The following is a description of a gene set: Genes down-regulated in CD4 T cells over-expressing FOXP3 and PPARg1 form of PPARG: untreated versus pioglitazone. Human Gene Set: GSE37534_UNTREATED_VS_PIOGLITAZONE_TREATED_CD4_TCELL_PPARG1_AND_FOXP3_TRASDUCED_DN Pioglitazone treatment of CD4+FoxP3- T cells transduced with Pparg and Foxp3 up-regulated a set of genes whose products have been implicated in lipid metabolism pathways. To verify the specificity of this treatment, we performed microarray analysis on Foxp3+Pparg1-transduced CD4+FoxP3- T cells after treatment with other PPARg agonists such as Rosiglitazone (TZD) and GW1929 (non-TZD). studied in species Homo sapiens from publication Cipolletta D, Feuerer M, Li A, Kamei N, Lee J, Shoelson SE, Benoist C, Mathis D (PMID 22722857), and this is the list of marker genes: CXCL10, MYD88, NAGK, KIF5C, ISG15, RNF19B, H2BC4, GTPBP2, GCH1, SYNRG, APOL2, FRS2, BRCC3, HERC6, MRPL17, GSDMD, CFLAR, STK19, GNAZ, WARS1, VAMP5, HLA-J, UBE2L6, JADE2, ERAP1, IFI30, TAP2, ATP10A, IFI35, CENPN, TMEM140, C1S, IFITM1, LGALS8, CARHSP1, CBR1, CASP1, OAS1, CRADD, FST, MT1M, STARD5, DCP1A, H3-3B, STAT1, HBD, GMPR, SLC15A3, MSC, RBCK1, TMBIM1, HAX1, RNF114, SIGIRR, COX17, TRAPPC14, ACAT2, IFITM3, CCL2, IRF9, TDRD7, DGLUCY, SLC25A40, CHRNB1, PLSCR1, LY6E, TRIM5, IFI44L, IFI27, TRIM21, EZR, FGF1, P2RX4, IRF7, PRKD2, GADD45B, GBP1, IFITM2, RPL13, NMI, PTPRA, BST2, IFIT2, STRADA, COBLL1, PSMB9, PTN, FANCF, DENND3, ATF3, PARP12, PML, TRIM38, IFI6 (NCBI Gene Id 2537), SLC25A28, TRIM26, COX4I1, IL10RB, CMTR1, RIGI, MX2, AFF4, TRPV2, IFI44, SCO2, LARS2, BAG1, OPTN, PTPRS, IL15RA, CPT1A, PDCD1LG2, TMBIM4, NAPA, APBA2, ANXA2P2, CREM (cAMP responsive element modulator), CEP85, S100A13, RAB20, FMOD, RSAD2, APOL6, SPAG4, HLA-E, RNF19A (NCBI Gene Id 81036), ELF1, OASL, HLA-C, PSMB8, TLR3, TRIB2 (NCBI Gene Id 28951), DHX9-AS1, TREX1, TRAFD1, RIPK2, EHD4 (NCBI Gene Id 30844), STAT2, DPP4, NDRG1, KDM4A, EXOSC9, USP18, MOK, FGF5, GCNT1, COASY, CADM1, CYB5R3, STT3A, RTP4, PSME2, TRIM25, IL6, BCL2L13, ABCF3, IFIT1, EIF2AK2, SNRPD2, PHACTR4, SP110, PODNL1 (podocan like 1), IFIT3, HERC5, HES1, SPSB1, OAS2, ID3, THEMIS2, CCL7 (NCBI Gene Id 6354), HLA-F, MTMR11, MID2, NBN, SHFL, XAF1 (NCBI Gene Id 54739), TRIM14 (tripartite motif containing 14), IRF1, STOML1, TXNIP, BCAT1, HK2, EFEMP2, PARP8, TMEM62, SPTLC2, MX1, CTNNBL1, SECTM1, SRGAP2, DDIT4, KRT7, SOCS1, OAS3, OGFR, PSMB10, TAP1, ZMAT5, CALR, ISG20 (interferon stimulated exonuclease gene 20)